Given this list of marker genes APPL1, SLC5A2, HNF1A, CEL (carboxyl ester lipase), ABCC8, SLC5A1, PAX4, GCK, HNF4A, KCNJ11, BLK, PDX1, KLF11, NEUROD1, INS, here is a description of the gene set: An abnormal resistance to glucose, i.e., a reduction in the ability to maintain glucose levels in the blood stream within normal limits following oral administration of glucose. species: Homo sapiens Abnormal oral glucose tolerance Human Gene Set: HP_ABNORMAL_ORAL_GLUCOSE_TOLERANCE